The following is a description of a gene set: from publication Chen Y, Wang X (PMID 31504780) Genes predicted to be targets of miRBase v22 microRNA mmu_miR_6353 in miRDB v6.0 with MirTarget v4 prediction scores > 80 (high confidence targets). Mouse Gene Set: MIR_6353 species: Mus musculus, and this is the list of marker genes: Rab9b, Slc4a8, Cfap45, Plxna2, Acvr2a, Zfp449, Slc13a3, Cdc25a, Prmt6 (NCBI Gene Id 99955), Ezh1, Ubr3, Cdk12, Syde2, Atp2b2, Qki, Pappa, Pacsin2, Tbl1xr1, Suco, Eya1, Seh1l, Fam151b, Stxbp3, Ppm1d, Unc80, Kif5c, Pex13, Usp42, Epha7, Casr, Med1, Phactr2, Sec61a1, Nynrin, Amotl1, Nudt7, Phf20, Axin2, Wnk3, Kif1c, Tenm2, Kcnk10, Plpp1, Sez6l, Fbln5, Slc4a4, Extl3, Ghr, Acvr2b, Zbtb44, Eda, Atxn1l, Ptpn3, Sema6d (NCBI Gene Id 98780), Cldn12, Ddx3x, Tab3, Btg2, Islr, Vegfa, Pam, Wee1, Cacul1, Cpeb3, Tlk1, 1700025G04Rik, Ppp6c, Smurf1, Cntnap1, Lhx3, Fasn, Rasgef1b, Arih1, Pnoc, Mapkap1, Sik1, Bcl2l2, Nectin1, Hephl1, Nol4l, Rnf10, Ppp2r1b, Rfx3, Zbtb39, Nudt4, Usp14 (ubiquitin specific peptidase 14), Sall1, Akap7, Rnf144b, Idh3a, Caprin1, Sema3a, Tacc1, Mgat4a, Nufip2 (NCBI Gene Id 78671), Cdk5r1, Kif5b (kinesin family member 5B), Zmym2, Ube4b, Kl, Wbp11, Reln, Penk, Plcxd2 (phosphatidylinositol-specific phospholipase C, X domain containing 2), Scoc, Ash1l, B3gnt6, Tbpl1, Kcnn4, Rictor, Tuba4a, Usp15, Dixdc1, Mybl1, Selenoi, Desi1, Cd2ap, Capn6, Spryd3, Hus1, Ccdc85b, Smim13, Ythdc1, Nfe2l1, Slitrk6, Ist1, Actr2, Kdsr, Spsb4, Kcnj2, Stradb, Ankrd46, Dcaf7, Il7r, Arhgap12 (Rho GTPase activating protein 12), Kif21a, Itpr1 (inositol 1,4,5-trisphosphate receptor 1), Ubfd1, Mmd, Ago1, Pik3r1, Plagl1, Raf1, Iars1, Ccne1, Grm7, Klc4, Abl2, Chpt1, Ubn2, Tll1, Helz, Bcl2, Arl2, Rab11fip1, Kpna1, Zbtb34 (NCBI Gene Id 241311), Atxn2, Satb2, Bace1, Ywhah, Map2k1, Myt1l, Peli3, Erlin2 (NCBI Gene Id 97480), Rarb, Arfgap2 (NCBI Gene Id 77038), Plxna4, Sall4, Ccnt2, Rbm6, Xpo7, Gm5460, Znrf2, Lrp6, Ippk, Clspn, Nuak2, Pth, Rfc1, Ahcyl2, Rubcnl, Sesn1, Gbp2b (guanylate binding protein 2b), Abtb2, Gm12886 (predicted gene 12886), Sec14l1, Krtap26-1, Plekhm3, Ptpn4, Atp1b4, Ccdc6, Chek1, Sox6, Chac1, Ret, Aff4, Cpeb2, Rasef, E2f3 (E2F transcription factor 3), Nrn1, Septin2, Abhd13, Phc3, Armcx6, Capns1, 6430571L13Rik, Atxn7l3, Myb, Fgf9, Crebl2 (cAMP responsive element binding protein-like 2), Wwp1, Btrc, Csrnp1, Arhgdia, Ccr2 (NCBI Gene Id 235692), Tmcc1, Slc20a2, Sptbn2, Gpatch8 (G patch domain containing 8), Kctd8, Cops7b, Dll1, Mfn2, Zfhx3, Zfp809, Atp7a, Bicd1, Zcchc3, Lrig1, Prkar2a, Cobll1, Rnf217 (ring finger protein 217), Sgk1, Armh4, 2810459M11Rik, Plxnc1, Tfap2a, Cdk17, Ptprr, Dsel, Ano3, Nos1, Hoxa10, Kif23, Cdca4, Slit2, Omg, Usp31, Dclk1, Aar2, Wnt3a, Ski, Adgrl1, Trabd2b, Cc2d1b, Insyn2a, Setd3, Rreb1, E2f7, Atf6, Krtap11-1, Pdxk, Tmem178b, Lats1 (large tumor suppressor), Rab10, Mob4 (MOB family member 4, phocein), Rad23b, Srpra, Cacna2d1, Ankrd13b, Pip4p1, Kif1b (NCBI Gene Id 16561), Kcnq5, Pwwp2b, Cpd, Pla2g15, Zfhx4, Rspo3, Reck, Erc2, Wipi2, Etnk1, Mex3c, Luzp1, Lrig2, Dll4, Tmem135, Nrbp1, Lurap1l, Mob3b, Colq, Tmem87b, Fgf7 (fibroblast growth factor 7), Nup210, Kmt2a, Prdm4, Zfp300, Col12a1, Shoc2, Cyp26b1, Trp53inp2, Sec24a, Apln, Lrrc32, Angel1 (NCBI Gene Id 68737), Slc39a10, Fbxw7, Smad7, Hectd4 (HECT domain E3 ubiquitin protein ligase 4), Pskh1, Pip4p2, Slc4a7, Slc25a22, Trank1, Spag7, Higd1a, Kbtbd2, Ints6l, Klhl2, B4galt1, Nlrx1, Wnt7a, Fmn2, Spred1, Man2a2, Cert1, Ncs1, Anks1, Phip, Usp25, Ncapg2, Pnpla6, Ccnjl, Akt3, Adissp, Ago4, Polr3f, Cbx4, Pappa2, Son, Klc1, Onecut2, Nav1 (NCBI Gene Id 408054), Fermt2, Cpsf7, Cdc37l1, Zyx, Fam135a, Fbxo21, Med26, Igf2r, Cbx6, Ube2q1, Jarid2, Adamts3, Acsl4, Chd2, Entpd7, Slc6a11, Hectd1, Adgrl2, G0s2, Ppm1e, Cmpk1, Phf19, N4bp1, Slc25a37, Tcaim, Rere, Fam110c, Socs6, Rubcn, Hapstr1, Zfp622, Dync1li2, Slc7a2 (NCBI Gene Id 11988), Zfp367, Dnajc16, Rad9a, Hmga1, Sel1l3, Tnrc6b, Crebrf, Dcp1a, Cbfa2t3, Zswim3, Akap11, Bmpr1a, Tmem74b, Cnot6l, Nfatc3, Drd1, Usp12, Ppp1r11, Prrc2c, Plekhh1, Tbp, Ttll6, Traf3, Dennd10, Btbd8, Adrb2, Pou2f1, Eif3a, Il10ra, Ccnd2 (cyclin D2), Avl9 (AVL9 cell migration associated), Gpr63, Ell, Clock, Pnp2, Garem1, Pafah1b1, Atg14, Tgfbr3, Htr4, Nup50, Gcc2